Given this list of marker genes SMO, ERBB3, SEMA3C, PIK3CG, FCN3, OPLAH, NRTN, ERBB2, GDNF (glial cell derived neurotrophic factor), FH, PIGY, MYH11, PLCG2, STAT1, EDNRB, IL10RB, DEF6, ECE1, DKC1, SLC37A4, IL10RA (NCBI Gene Id 3587), ELANE, SEMA3D, NOP10, NLRC4, RET, ATP7A, ACADVL, ABCD1, SREBF1, TTC7A, EDN3, here is a description of the gene set: Human Gene Set: HP_ENTEROCOLITIS An inflammation of the colon and small intestine. However, most conditions are either categorized as Enteritis (inflammation of the small intestine) or Colitis (inflammation of the large intestine). studied in species Homo sapiens Enterocolitis